The following is a description of a gene set: Pathway Definition from KEGG: Fe2+ -- CP -> Fe3+ -- (TF+TFR1) -> Fe3+(endosome) -- STEAP3 -> Fe2+ -- (DMT1,ZIP8/14) -> Fe2+ Human Gene Set: KEGG_MEDICUS_REFERENCE_FE_TF_TRANSPORT studied in species Homo sapiens Fe-TF transport. Pathway ID: N01587. Pathway type: Reference. Pathway class: nt06525 Ferroptosis., and this is the list of marker genes: STEAP3, SLC11A2, SLC39A8, TFRC, TF (transferrin), SLC39A14, CP